Given this list of marker genes CFAP298 (cilia and flagella associated protein 298), DRC1, ARL2BP, CFAP300 (NCBI Gene Id 85016), DNAH11, OFD1, TTC12, SPEF2, ODAD2, NPM1, FIP1L1, DNAAF2 (dynein axonemal assembly factor 2), ODAD4, NUMA1, DNAH1, STAT5B, LRRC56, TBL1XR1, SCNN1G, RARA, ODAD3, ZBTB16, DNAAF11, DNAI1, CFAP74, DNAAF5, DNAAF4, DNAAF1 (dynein axonemal assembly factor 1), NEK10, BCOR, PML, RSPH4A, IRF2BP2, MCIDAS, DNAH5 (NCBI Gene Id 64774), CCDC39, ZMYND10, DNAAF3 (dynein axonemal assembly factor 3), GAS2L2, RSPH9, FOXJ1, RPGR, CCDC40, RSPH3, CFAP221, NABP1, DNAI2, STAT3, DNAH9, STK36, NME8, SCNN1B, ODAD1, RSPH1, CFTR, DNAJB13, DNAAF6, SPAG1, DNAL1, HYDIN, NME5, PRKAR1A, CCNO, SCNN1A, BRWD1, here is a description of the gene set: species: Homo sapiens Productive cough Human Gene Set: HP_PRODUCTIVE_COUGH A cough that produces phlegm or mucus.